The following is a description of a gene set: Any process that modulates the frequency, rate or extent of tooth mineralization, the deposition of calcium salts in tooth structures. studied in species Homo sapiens Human Gene Set: GOBP_REGULATION_OF_TOOTH_MINERALIZATION, and this is the list of marker genes: BCOR, AMTN, TFAP2A, TGFB1, SLC4A2, ASPN, ENAM, ODAPH, DMP1, AMELX, CFTR, WNT6, MMP20